Given this list of marker genes FOSL2, BHLHE40, JUNB, HES1, BTG2, RBMS1, MAFF, ID1, NAB2, KLF6, FOSL1, ATF3, ZFP36L2, ZFP36L1, KLF10 (KLF transcription factor 10), ZFP36, PIAS1, CREM, here is a description of the gene set: Signaling pathways invoke interplays between forward signaling and feedback to drive robust cellular response. In this study, we address the dynamics of growth factor signaling through profiling of protein phosphorylation and gene expression, demonstrating the presence of a kinetically defined cluster of delayed early genes that function to attenuate the early events of growth factor signaling. Using epidermal growth factor receptor signaling as the major model system and concentrating on regulation of transcription and mRNA stability, we demonstrate that a number of genes within the delayed early gene cluster function as feedback regulators of immediate early genes. Consistent with their role in negative regulation of cell signaling, genes within this cluster are downregulated in diverse tumor types, in correlation with clinical outcome. More generally, our study proposes a mechanistic description of the cellular response to growth factors by defining architectural motifs that underlie the function of signaling networks. from publication Amit I, Citri A, Shay T, Lu Y, Katz M, Zhang F, Tarcic G, Siwak D, Lahad J, Jacob-Hirsch J, Amariglio N, Vaisman N, Segal E, Rechavi G, Alon U, Mills GB, Domany E, Yarden Y (PMID 17322878) Human Gene Set: AMIT_DELAYED_EARLY_GENES Delayed early genes (DEG) which are coordinately down-regulated in multiple epithelial tumor types. species: Homo sapiens